The following is a description of a gene set: Human Gene Set: REACTOME_PTK6_REGULATES_PROTEINS_INVOLVED_IN_RNA_PROCESSING studied in species Homo sapiens PTK6 Regulates Proteins Involved in RNA Processing, and this is the list of marker genes: KHDRBS2, KHDRBS3, SFPQ, PTK6, KHDRBS1